The following is a description of a gene set: Human Gene Set: GOMF_ATP_DEPENDENT_PROTEIN_FOLDING_CHAPERONE species: Homo sapiens Binding to a protein or a protein-containing complex to assist the protein folding process, driven by ATP hydrolysis., and this is the list of marker genes: CLPX, HSPA4, CCT2, HSPD1, HSPH1, CCT8, CCT8L1P, HSPA7, HSP90AA5P, HSPA4L, CCT7, HYOU1, HSPA13, HSP90AA1, HSPA2, HSPA1B, CCT3, HSP90AB1, HSPA8, HSP90AA4P, CCT6B, TRAP1, CCT4, CCT5, HSP90AB4P, CCT8L2, HSP90AA2P (heat shock protein 90 alpha family class A member 2, pseudogene), HSPA5, HSPA9, HSP90AB3P, HSPA1A, HSP90AB2P, TCP1, HSPA1L, HSP90B2P, TOR1A, HSPA14, HSP90B1, HSPA6, CCT6A